The following is a description of a gene set: from publication Cui A, Huang T, Li S, Ma A, Pérez JL, Sander C, Keskin DB, Wu CJ, Fraenkel E, Hacohen N (PMID 38057668) Mouse Gene Set: CUI_PDC_IFNB_RESPONSE_UP Cytokines mediate cell-cell communication in the immune system and represent important therapeutic targets. A myriad of studies have highlighted their central role in immune function, yet we lack a global view of the cellular responses of each immune cell type to each cytokine. To address this gap, the authors created the Immune Dictionary, a compendium of single-cell transcriptomic profiles of more than 17 immune cell types in response to each of 86 cytokines (>1,400 cytokine-cell type combinations) in mouse lymph nodes in vivo. A cytokine-centric view of the dictionary revealed that most cytokines induce highly cell-type-specific responses. For example, the inflammatory cytokine interleukin-1β induces distinct gene programmes in almost every cell type. A cell-type-centric view of the dictionary identified more than 66 cytokine-driven cellular polarization states across immune cell types, including previously uncharacterized states such as an interleukin-18-induced polyfunctional natural killer cell state. species: Mus musculus Genes positively differentially expressed in cell type: pDC (plasmacytoid dendritic cell) upon treatment with cytokine: IFN-β in mouse lymph nodes in vivo., and this is the list of marker genes: Rnf34, Scand1, Tmem86a, B2m, Ifit1, Usp18 (ubiquitin specific peptidase 18), Tubb4b, Il2rg, Adar, Setd3, Paqr5, Phyh, Ncf1, S100a6, Carmil1, Cmpk2, Ube2d2a, Dnajc7, Cd164, Calhm6 (NCBI Gene Id 215900), Cbx5, Cdc42, Psmb6, Phf11b, Znfx1, Ptpn6, Ldlr, Il17rb, Lrp8, Exosc3, Rbm3, Cd82, Tomm70a, Zc3hav1, Slc15a3, Sar1a, Tap2, Sec61g (NCBI Gene Id 20335), Pcyt1a, Serpina3g, Pgap2, Rbms1, Treml2, Anxa7, Chtop, Irf1, Gna15, Necap2, Ifi44, Rnf114, Gadd45b, Esyt1, Mycbp2, Dnajc13, H2-Q7, Gbp7, Sfxn2, Lamp2, Ly86, Ube2l3, Cdh1, Rac2, Vim, Ifit2, Rnase6, Isg20, Prkcd, Tpm3, Ppa1, Casp4, Iqgap1, Ifi205, Fcer1g, Atp1b3, Cd40, Scarb2, Rasa4, Usp25, Cxcl10 (C-X-C motif chemokine ligand 10), Gbp4, Smg7 (NCBI Gene Id 226517), Akt3, Ifi214, Sp100, Lrrc59, Edem2, Cybb (NCBI Gene Id 97621), H2-D1, Snx2, Tuba1b (NCBI Gene Id 22143), Irf7, Dnajb11, Derl2, Parp14, Reep3, Napsa, Manf, Tor3a, Actr2, Pttg1, Tcstv4, Trim30b, Cebpb, Nmi, Lgals3 (NCBI Gene Id 16854), Cnp, Ccnd1, Txn1, Psmb8, Cyth1, Armcx6, Trp53i11, Srsf5, Tap1, Dynll2, Stat1, Isg15, Isoc1, Acadl, Slfn5, Gramd2b, Parp9, Sdc4, Dtx3l, Reep5, Sh3bgr, Arf4, Ms4a6c, Sp140 (NCBI Gene Id 434484), Lacc1, Shisa5, Kdr, P4ha1, Cycs, Capg, Oas1a, Pml, Atp6v1g1, Ifitm3, Cotl1, Nlrc5, Fndc3a, Eif2ak2, Parp11, Cpne2, Ifi203, Ptms, Igtp, Tdrd7, Entpd1, Arid3a, Fdps, Mthfr, Hspa8, Ntrk1, Anxa4, Ifi47, Pfkp, Hsp90ab1, Trim30a, Vwa5a (NCBI Gene Id 67776), Clec2d, Etnk1, Creb3, Ppp1r2, Vrk1, Oasl1, Pnp, Hmgn3, Epsti1, Helz2, Xrn1, Mx1, Trim12c (tripartite motif-containing 12C), Atf4, Slfn2, Xaf1, Ube2l6, Ifih1, Nfkb2, Emc8, Oas3, Tubb2a, Herc6, Phf11d, Ifi35, Tagln2, LTO1, Ifi209, Chmp4b, Cpne3, Gng12, Ly6a, Asb13, Ifi208, Mpeg1, Marchf5, Tapbp, Ifi211, Mtf1, Pdia3, Samd9l, Clec9a, Cd86, Svbp, Actr3, Rtp4, Tnfsf10, Atp13a1, H2-T24, Ascc3, Dbnl, Apod, Gch1, Ifi204, Tmem219, Arfgap3, Edem1, Daxx, Phf11a, Capn1, Bbx, Xbp1, Mat2a, Actg1, Smim6, Spib, Gnb1, Plaat3, Pmepa1, Iigp1, Psme1, Slc2a6, Psma2, Ass1, Oasl2, Atp8a1, Psmc2, Rragc, Trafd1, Pfn1 (NCBI Gene Id 18643), Jaml, Tapbpl, Ppif (peptidylprolyl isomerase F (cyclophilin F)), Rap1a, Klrk1, Lgals9, Calm1, Rngtt, Igkc, Mef2a, Samhd1, Ccnd3, Otud5, Gbp6, Parp12, Anxa6, Slc25a22, Stau2, Elf4, Ywhah, Stat2, Mndal, Dnaja1, Snrnp27, Psmb9, Coro1a, Rnf213, Frmd4a, Gbp8, Parp3, Sh3glb1, Lgals3bp, Bst2, Srsf3, Ly6c2, Hspa5, Serpini1, Ppp1r11, Tmem184b, Tmsb10 (NCBI Gene Id 19240), Ndufa11, Sp110, Acer3, Ifi213, Aida, Csrp1, Il21r, Klk1, Rsad2, Psma5, Tor1aip1, Ergic1, Cdk14, Ifi27l2a, Grn, Bcl11a, H2-T22, Dck, Ifi207, Plaur, Idi1, Atp6v1d, Nampt, Zbp1, Tspo, Irgm1, Sgcb, Tnpo3, Psme2, Fam3c, Nono, Ms4a4c, Sct, Tspan31, Pkib, Hsp90aa1, Trim30d, Cfap210, Sdc3, H2-T23 (histocompatibility 2, T region locus 23), Ctsl, Psma7, Micos10, Casp3, Inpp5b, Tmbim6, Cd47, Nt5c3, Ube2n, Taldo1, Eif1, Mpc1, Cpped1, Plac8, Tpm4, Nrp1, Washc4, Dynll1, Gtf3c6, H2-K1, Pgd, Hivep3, Selenow, Utrn, Dhx58, Hck, Ifit3, Tlr7